The following is a description of a gene set: from publication Chen Y, Wang X (PMID 31504780) Genes predicted to be targets of miRBase v22 microRNA hsa-miR-4639-3p in miRDB v6.0 with MirTarget v4 prediction scores > 80 (high confidence targets). species: Homo sapiens Human Gene Set: MIR4639_3P, and this is the list of marker genes: LGR5, CABCOCO1, WDR33, NRG1, PSAT1, ZNF354B, CTNNA3, ZNRF3, MTURN, BNC2, TIA1, MLLT6, CCN2, SH3BP2, ZCCHC17, AGO2, DGKE, VEPH1, FMN1, SGSH, NXF1, TSC22D1, CNEP1R1, ARHGEF7, NUS1, LYSMD4, TLNRD1, LINC02694 (NCBI Gene Id 400359), VHL, TDRD10 (tudor domain containing 10), MAP1B, NIFK, SLC24A2, BHLHE22, NLGN4X, TXNDC16, TMTC3, SLC6A5, DCUN1D1, ZNF597, MAP7, KCNK1, STEAP3, RBBP4, DPH6, CUX1, YPEL2, SPN, PTGER3, ALG1, MCMDC2, RSAD1, ZCCHC10, AFG2A, KBTBD2, EMX2, TSPAN5, PPM1L, USP37, ZNF484, KCNMA1, TMED7, NSL1, ENC1, CDS1, C6orf47, RABIF, ZNF287, MASP2, CAPZA1, DLG4, VDR